Given this list of marker genes PLAGL2, LIMK2 (LIM domain kinase 2), EYA1, ATRNL1, CITED2, RUNX1T1, MYOCD, GARNL3, KCTD15, ELMOD1, PDE1A, RALYL, CLIP2, CBLN1, AMFR, STAG2, IKZF5, RUNX1, DLX4, CSPP1, NFIL3, VGLL4, SH2D4A (NCBI Gene Id 94368), INTS8, RSF1, THRB, PHF6 (NCBI Gene Id 84438), TFEC, KANSL1L, CLMN, TSHZ3, FEV, BCL2, HIPK1, PLCB1, GRHL2, POP7, HOXC10, EAPP, INO80, ACACA, ST13P5, CNOT1, AURKA, SOX10, ASPA, CTNND1, ST6GALNAC5, LMO3, CACNA1E, CYRIA, STARD13, CITED1, ACSL4, ZNF641, HOXA3, ZNF521, CRYGB, APEX2, SATB1, FGB, POFUT1 (NCBI Gene Id 23509), EDA, VEZF1, COG2, RBM39, ELMO1, ARL4C, ZIC2, GRIN3A, PRDM1, AP1S2, GABARAP, TFDP2, PLP2, ZIC3, RTL9, BTG3, RPS14, NDC80, GJB4, NOG, TTC29, PPP6R3, DPP10, RGS3, METTL4, NOTCH2, SHOX2, CACNA1G, ABCB5, TRIM68, EDC4, PDE1C, OVOL1, FAM120AOS, ADAMTS5 (NCBI Gene Id 11096), FES, COL1A1, HOXA7, ABLIM1, SEMA3A, TOB1, VAX1, ZHX2, UBR5, NOTCH2NLA, CSTF1, CAPNS2, RASGRF1, CNTNAP2, FAM120A, PPP2R5E, FAM110B, BEND4, MON1A, CALD1, AR, ARHGDIB, CKM, CPEB4, GPC4, CCDC91, RGS8, LUC7L3, CHD2, FAM72A, ST13P4, FIGN, SORBS2, TPM2, CAMK1D, NUB1, AAMDC, ELOA2, ARHGEF39, ARL6IP1, ITPR1, SLC2A12, NUMB, ADARB2, ITPRIPL1, PKP4, LINC00487, EIF2B3, KLHL13, HOXB8, FSBP, HAX1, ETV1, C1orf116, LRMDA, ZNF148, PPP1R3A, STC2, CDC25A, CELF4, CENPN, ZNF638, FOXN3, WNT5A, SERTAD1, INSM1, HNRNPA0, JMJD1C, TYRO3, GLT8D2, NTRK3, SP4, SMIM14, GRIN1, ROR1, TNMD, AXIN2, BCL9, RAPH1, KIF13A, MXI1, HS3ST4, TGM4, KCNMB2, MITF, PLEKHA5, GNAO1, SOX14, PCDH10, GPR150, TAB2, KLF9, GPATCH11, KRTAP17-1, TMTC2, HOXC6, GPR156, ZBTB37, S1PR1, EMP1, SOX2, OSBPL9, TBX2, CHRDL1, SKA2, MAP2K7, HOXC4, PIK3R1, ACADSB, SMURF2, FGF9, CPNE1, ZBTB9, TNR, KIF20B, ELOVL6, CD44, KDM6A, R3HDM2, IRAK1, CAVIN2, PELO, NTRK1, DMD, IKZF2, CES5A, ACVR1, CA10, PPP2R5A, TPCN2, FRA10AC1, FAM53C (NCBI Gene Id 51307), CBLB, SOX5, LRRC4, LHX6 (LIM homeobox 6), POU3F1, BARHL1, KAZALD1, RAD51AP1, PRR11, OGG1, CAPRIN1, FLRT3, ITGB6, CWF19L2, EHD4, HOXC12, TSC22D2, GPR15, SLC33A1, MIA2, RBM47, HOXA9, KAT7, BPIFA3, CHMP1B, CHD6, CSNK1A1L, ENPP2, RORB, GABRA4, MAML3, HAPLN2, CALM1, PCYT1B, DCUN1D1, CHMP2B, SPINK5, SLC24A2, DOCK4, CYBB, CD96, PPP1R14C, RBM14, DCTN1, TMOD4, BHLHE41, LMO4, GADD45G, EOMES, NFIX (nuclear factor I X), DNAI3, HOXB4 (homeobox B4), ITGA1 (NCBI Gene Id 3672), CLN5, TPPP3, BMP4, OXGR1, LY6G5B, BRCA2 (BRCA2 DNA repair associated), KCNJ2, SFRP2, CMC2, NEUROD2, DSCAM, PDZRN4, NEDD4, ZNF277, NR1D1, GABRG2, OFCC1, BAIAP2L1, PBX1, NFIB, HID1, DYNC1H1, RIPK4, RYR1, NKX2-2, ACTA1, KCNK5, CYP26B1, ATP2A2, PRKAG1, CEP41, ZMYND8, NEUROD6, PLEKHS1, AGTR2, LHX2, OTP, SLC5A3, HNF1A, DEF6, KCNE4, GPHB5, HSH2D (hematopoietic SH2 domain containing), HS3ST1, WEE1, CHL1, NECAP1, DENND4C, SYTL2, SRSF6, POU3F3, FMR1, PNOC, DSG1, ZNF768, DLC1, UGGT1 (NCBI Gene Id 56886), SMARCA2, PGRMC1, THSD4, DUSP10, MAGI1, EXOC4, S100PBP, TAL1, SLC39A12, FERRY3, MAP2K5, OLFML3, DAAM1, TCF12, WNT2B, HTR2C, CHN2, NIPBL, OMD, PIK3CD, BDNF, PTPRD, FOXP2, ZFPM2, IFIH1, HIC2, SEC24D, ESRRG, NRXN3, COL9A1, PAN2, TSHZ2, DIS3L, LRRC8D, WDTC1, MYOG, OMG, here is a description of the gene set: Comprehensive identification of all functional elements encoded in the human genome is a fundamental need in biomedical research. Here, we present a comparative analysis of the human, mouse, rat and dog genomes to create a systematic catalogue of common regulatory motifs in promoters and 3' untranslated regions (3' UTRs). The promoter analysis yields 174 candidate motifs, including most previously known transcription-factor binding sites and 105 new motifs. The 3'-UTR analysis yields 106 motifs likely to be involved in post-transcriptional regulation. Nearly one-half are associated with microRNAs (miRNAs), leading to the discovery of many new miRNA genes and their likely target genes. Our results suggest that previous estimates of the number of human miRNA genes were low, and that miRNAs regulate at least 20% of human genes. The overall results provide a systematic view of gene regulation in the human, which will be refined as additional mammalian genomes become available. species: Homo sapiens Human Gene Set: YNGTTNNNATT_UNKNOWN from publication Xie X, Lu J, Kulbokas EJ, Golub TR, Mootha V, Lindblad-Toh K, Lander ES, Kellis M (PMID 15735639) Genes having at least one occurrence of the highly conserved motif M170 YNGTTNNNATT in the regions spanning 4 kb centered on their transcription starting sites. The motif does not match any known transcription factor binding site.